Given this list of marker genes Nppa, Stab2, Acap2, Smap2, Tmtc4, Map3k1, Als2cl, Oprl1, Reck, Sec24a, Ift122, Rtl4, Rtn4, Slc35d3 (solute carrier family 35, member D3), Zbtb18, Btg1, Iqca1, Adamts4, Usp24, Hnrnpa0, Brpf3, Spata1, Crocc2, Ppip5k1, Klhdc1 (kelch domain containing 1), Lin54, Brwd3, Poc5 (NCBI Gene Id 67463), Pim1, Rims2, Mfsd14a, Syncrip, Htr1f, Arid3b, Scfd1, Kcnd2, Dcc, Nrf1, Gpr37 (NCBI Gene Id 269834), Sorbs2, Kcmf1, Kcnj3, Skint4, Lipg, Tcte1, Fez2, Rfwd3, Ppt1, Tbc1d20, Dnmt3a, here is a description of the gene set: from publication Chen Y, Wang X (PMID 31504780) Genes predicted to be targets of miRBase v22 microRNA mmu_miR_3070_2_3p in miRDB v6.0 with MirTarget v4 prediction scores > 80 (high confidence targets). Mouse Gene Set: MIR_3070_2_3P studied in species Mus musculus